The following is a description of a gene set: A process in which a protein is transported to, or maintained in, a location within a ciliary transition zone. Human Gene Set: GOBP_PROTEIN_LOCALIZATION_TO_CILIARY_TRANSITION_ZONE studied in species Homo sapiens, and this is the list of marker genes: CC2D2B, NPHP4 (NCBI Gene Id 261734), CC2D2A, TCTN2, MAPK15, TCTN1, TMEM107, SPATA7